Given this list of marker genes MYO5A, PIK3R1, GEMIN2, TTC39B, UGT3A1, CDC14A, MEX3C, WDR47 (NCBI Gene Id 22911), CAMTA1, TMED7, TOP2B, SV2B, RAD23A, GKAP1, FLI1, SPOPL, CAVIN4, PIAS1, RAPH1, PTBP3, MEF2A, ZDHHC21, MAFB, POU4F1, GUCY1A1, MINDY2, ZFPM2, FOXJ3, CCNYL1, ZFR, MAP4, DDX3X, ZFAND4, TPBG, GTF2A1, ABHD6, TMEM33, NRK, ZNF569, PI4KB, CSK, PEX13 (peroxisomal biogenesis factor 13), TFRC, OTUD6B, DDHD1, TDG, NTN4, CPNE8, RBFOX1, SOWAHC, NUDT12, AFG2A, CNEP1R1, USP38, MACF1, MYEF2, ENTPD1, TMEM245, KMT2D, GPR22, PIGN (NCBI Gene Id 23556), FAM76A, TXNRD1, ARPP19, CNBP (NCBI Gene Id 7555), NF1, KDELR3, RAB27B, USP33, TRMT5, SLC6A11, GPR63, HACD3 (NCBI Gene Id 95112), VMA21, GFRA1, SPIN4, MPHOSPH9, ITPRID2, SERBP1, RPP30 (ribonuclease P/MRP subunit p30), CFHR5, BOLL, SMAD4 (NCBI Gene Id 4089), NDUFC2-KCTD14, PIK3CB, HTR5A, ATP2A2, MCC, PHIP, SREK1, UGGT1, FNIP2, FGG, BEX2, ITGAV, GPAM, ZNF260, ADAM22, B3GLCT, XPO4, SDE2 (SDE2 telomere maintenance homolog), RGS3, ZFHX3, ARID4A, DYNC1LI2, CTTNBP2, SLC1A3, FBXO22, ADAMTS5, CDYL, KLHL15, CDC42BPB, MOB1B, PURB, CNTN4, WDTC1, GABRB1, SEC62, BMPR2, FAM3C (FAM3 metabolism regulating signaling molecule C), NAV3, TRAPPC8, ZNF229, KANSL1L, DSG2, SYNDIG1L, REST, UBR2, TBP (NCBI Gene Id 6908), CELSR1, RPGRIP1L, TRMT10A, PCBP2, USP48, TLNRD1, SRCIN1, PDE7B, INTS15, ARL8B, TET1, LRRTM3, TMEM169, GPR137B, MYO1B, ADH5, ADPRH, ANGEL2, OTX2, CCAR1, ARHGAP21, OTULINL, ENPP2, PCGF5, TSTD2 (thiosulfate sulfurtransferase like domain containing 2), NHLRC2, STXBP5, KIF2A, RAB22A, ADSS2, DSC2, DTD2, UTP23, BRWD3, OSBPL8, CALB1 (calbindin 1), OPRM1, GNAO1, PMS1, LYRM7, ATF7IP2, C1orf131, BTF3, G3BP2 (NCBI Gene Id 9908), ZNF658, SLC25A24, TRAPPC1, LUC7L2, PLAGL1, CALM1, CDK6, GTF2IRD2, CPD, PTPN12, ARL6IP1, BCOR (BCL6 corepressor), PHF3, CFAP418, EGFL8, CXXC4, PAG1 (phosphoprotein membrane anchor with glycosphingolipid microdomains 1), EIF1, PPM1D, MAP3K2, SCML1, HERC4, TMEM236, MMP2, PHC3, HERC1, OSM, SCAI, ATXN3, ADIPOQ, CXCR4, HAPLN1, VPS13C, GPR85, IREB2, WASF1, CCL28, TAOK1, IFT81, CHCHD7, WAPL, CPNE3, ZFX, TAF9B, ZNF713, HACE1, ZNF333, PPM1B, PHF6, PHF20L1, ADAMTSL3, ZBTB41, FZD4, APELA (apelin receptor early endogenous ligand), KLF9, MSI1, CEP85L, SPINK7, MECP2, SESN3, ZDBF2, CENPH, ZPLD1, U2SURP, PCBP1, CHST14, MTX3, VASP, ELK4 (NCBI Gene Id 2005), EHMT1, TGFBR3, NEXMIF, ZZZ3, C4orf51, RUFY2, ZNF281, CD47, EZR, SLC25A36, NFAT5, SP3, TBL1XR1 (NCBI Gene Id 81612), ZNF91, TENT4B, ATF2, ZYG11B, XRN2 (5'-3' exoribonuclease 2), ERBIN, SPIRE1, CLASP2, ZNF264, ATRX, DCC, GTF2IRD2B, JAKMIP2, LINC02801, SERINC5, PCNA, HS3ST3A1, RAB31, CREB5, COX15, DNAJC27, SKIL, GRIA3, TP53INP1, FAM149B1, PCBP4, SUB1, DKK3, INO80D, KAZN, FTO, GABRG1 (gamma-aminobutyric acid type A receptor subunit gamma1), MSL2, STAM2, PCGF3, SRSF11, RSBN1, ZEB1, RNF19A, TMED4, FBXW7, DENND4C, AMPH, GADD45A, COMMD3-BMI1, GALNT1, ZFYVE28, EIF4E, ACYP2, MIER3, ADGRB3, TTPA, MFAP3L, DIDO1, MTF1, GEMIN5, ETNK1, ZNF275, VEZT, TRPM7, PDS5B, PIKFYVE, SLC26A4, JAKMIP3, RNF38, NUAK1, TCF20, DR1, ZCCHC10, ARHGAP6, TM9SF2, FOXO3, PCDH11X, GPC4, PDE10A, SGIP1, ACKR3, ADAM10, LPP, WDR17, EVI5, EBF2, THUMPD1, RAPGEF5, SPRED1, FTHL17, PCLO, TSPAN2, ALKBH5, KBTBD8, MAP7, TAB2, BRWD1, ST18, ATL1, LTBP1, HLTF, PCDH7, P3R3URF-PIK3R3, KCNC1, MMAB, HNRNPUL2, LEPROT, RNF168, NSD2, PAPOLA, PGM2L1, NEMF, PIK3CG, PPP6R3, SOCS6, GABPB1, B4GALT6, MEX3D, NNT, C3orf70, ATXN7, GCSAML, QKI, GNS, CCDC186, HLF, CDCA4, BBS5, TP53BP1, ALS2, RNPS1, FZD3, PAK2, ARK2N, ACVR1C, PAIP1 (NCBI Gene Id 10605), PLEKHB2, EDEM3, LATS1, ZFHX4, SGCZ, SCHIP1, B3GAT1, FERMT2, ZNF681, RNF14, ZBTB14 (zinc finger and BTB domain containing 14), PIP4K2A, CUL3, CNOT6L, RNF207, IPMK, CSTF3, RAD51AP1, ZNF148, TEAD1, NEK7, PPP3R1, PIK3R3, RNF2, IKZF2, ZNF280C, SULT1C4, PRRC1, TNRC18, TNPO1 (transportin 1), SLCO4C1, ATRNL1, MED4, SLC2A13, CDK13, PTBP2, PTEN, ATXN1, N4BP2L1, USP31, MED28, TPR, SOX9, PABPC5, ANKRD11, IKBIP, ACVR2B, PNPLA4, CNTN1, ANKRD55, PBX2, TOP2A, SMNDC1, ZMYND19, CNTNAP2, SLC4A4, CSDE1 (cold shock domain containing E1), MPZL2, TET2, WASHC3, NR3C2, GNB2, STK39, PLCH1, HYPK, SLC44A5, TSPAN16, TNRC6B, PARP16, UBE2G1, EPC1, ONECUT2, IQCJ-SCHIP1, SAMD8, UQCC6, ZBTB20, ENOPH1, DMD, SERTAD2, RPS6KB1, ZBTB44, ATP11C, ESYT2, TRUB1, HECTD2, PSIP1, ELAVL1, SNRPD1, PLPPR1, ZC3H12C, ZNF711, DGKH, KANSL1, KLHL28, STRBP, VPS37A, NEURL3, ZNF484 (zinc finger protein 484), INHBB, here is a description of the gene set: studied in species Homo sapiens from publication Chen Y, Wang X (PMID 31504780) Genes predicted to be targets of miRBase v22 microRNA hsa-miR-548e-3p in miRDB v6.0 with MirTarget v4 prediction scores > 80 (high confidence targets). Human Gene Set: MIR548E_3P